The following is a description of a gene set: species: Homo sapiens part of: Translation The process for translation of a protein destined for the endoplasmic reticulum (ER) branches from the canonical cytoslic translation process at the point when a nascent polypeptide containing a hydrophobic signal sequence is exposed on the surface of the cytosolic ribosome:mRNA:peptide complex. The signal sequence mediates the interaction of this complex with a cytosolic signal recognition particle (SRP) to form a complex which in turn docks with an SRP receptor complex on the ER membrane. There the ribosome complex is transferred from the SRP complex to a translocon complex embedded in the ER membrane and reoriented so that the nascent polypeptide protrudes through a pore in the translocon into the ER lumen. Translation, which had been halted by SRP binding, now resumes, the signal peptide is cleaved from the polypeptide, and elongation proceeds, with the growing polypeptide oriented into the ER lumen. Reactome Pathway: SRP-dependent cotranslational protein targeting to membrane, and this is the list of marker genes: SEC61B, RPL37, RPN1, RPN2, RPS27, RPL3L, RPS18, RPS26, RPL22, 5.8S rRNA, RPL19, SEC61A2, RPS7, SEC11A, RPS4Y2, RPL22L1, RPL9, RPS8, SPCS1, RPL26, RPS15, RPS5, SRP14, SEC11C (NCBI Gene Id 90701), FAU, RPL15, 7SL RNA (ENSG00000222619), RPS16, RPS4Y1 (NCBI Gene Id 6192), RPL14, SRPRA, RPS4X, RPS24, RPS2, RPSA, RPL41, UBA52, RPL4, RPL10, RPL13A, SEC61A1, RPL36 (NCBI Gene Id 92364), DDOST, RPL26L1, RPL11, RPS12, SRP19, 28S rRNA, SEC61G, RPL38, RPS15A, RPS10, 5S rRNA, RPL13, RPL10A, RPL28, RPS11, RPS19, RPLP2, RPL23A, 18S rRNA, RPLP1 (NCBI Gene Id 6176), RPS14, SSR2, RPS28, SSR1, RPL31, RPL5, RPS27L, RPS27A, RPL8, RPL35, RPS21, RPL12, RPL36AL, RPS3, SRP72, RPL17, RPS29, RPL18, RPL6, RPL23, RPL35A, RPS17, RPL39, RPL27, RPL34, SSR3, TRAM1, RPL7, RPS25, RPL32, RPL7A, RPL37A, RPS20, RPL29, SRP68, RPS13, RPS9, RPL18A, SRP9, RPS3A, SPCS2, SPCS3, RPL36A, RPL21, SRP54, RPL27A, RPLP0, SSR4, RPL24, RPL10L, RPL3, SRPRB, RPL30, RPS23, RPL39L, RPS6, 7SL RNA (ENSG00000222639)